The following is a description of a gene set: Human Gene Set: HP_HYPERECHOGENIC_PANCREAS Hyperechogenic pancreas species: Homo sapiens, and this is the list of marker genes: EFL1, ASXL1, DNAJC21, PTRH2, NPHP3